Given this list of marker genes Hoxa11, Rfng, Fanca, Ccnd2, Prdm1, Mbd1, Stat5a, Gadd45b, Ncstn, Bmi1, Btg3, Vsx2, Irf6, Psen2, Xbp1, Mxi1, Pik3cg, Myc, Hoxc13, Prkcd, Hes3, Tnfsf13b (NCBI Gene Id 52115), Traf3, Fzd6, Irf4, Akt1, Mib1, Pou2af1, Socs2, Dtx2, Fosb, here is a description of the gene set: Aside from Myc-activating translocations characteristic of plasmacytomas (PCT), little is known about genetic factors and signaling pathways responsible for the development of spontaneous B-cell lineage lymphomas of mice. Here, we characterized the transcriptional profiles of PCT, centroblastic diffuse large B-cell lymphomas (CBL), and high-grade splenic marginal zone B-cell lymphoma (MZL++) using high-throughput quantitative reverse transcription-PCR. Expression profiles of CBL and MZL++ were strikingly similar and quite unlike that of PCT. Among the genes expressed at significantly higher levels by PCT were a number involved in NOTCH signaling, a finding supported by gene set enrichment analyses of microarray data. To investigate the importance of this pathway, NOTCH signaling was blocked in PCT cell lines by treatment with a gamma-secretase inhibitor (GSI) or transduction of a dominant-negative mutant of MAML1. These treatments resulted in reduced expression of NOTCH transcriptional targets in association with impaired proliferation and increased apoptosis. GSI treatment of transformed plasma cells in a primary PCT also induced apoptosis. These results integrate NOTCH activation with oncogenic signaling pathways downstream of translocated Myc in the pathogenesis of mouse PCT, two signaling pathways also implicated in development of human multiple myeloma and T-cell lymphoblastic lymphoma. Mouse Gene Set: SHIN_B_CELL_LYMPHOMA_CLUSTER_2 from publication Shin DM, Shaffer DJ, Wang H, Roopenian DC, Morse HC 3rd (PMID 19010892) Cluster 2 of genes distinguishing among different B lymphocyte neoplasms. studied in species Mus musculus